Given this list of marker genes PFKFB3, GPD1L, ERICH3, RAP1B, ACTC1, TTC9, NRXN1, TMEM168, PPP3R1, PRDM1 (NCBI Gene Id 639), IKZF2, PHACTR2, TPD52L1, CCDC141, GGACT, SLC16A7, GABRA1, TAOK1, LCA5, GJB7, GABRA5, MAPK1IP1L, BTAF1 (B-TFIID TATA-box binding protein associated factor 1), GPR148, STARD4, ANO4, PNRC2, MTMR2, RAB3IP, AKAP12, ARL17A, PCDH10, EPHA3, RPGRIP1L, LARP1B, SUZ12, CLDN1 (NCBI Gene Id 9076), SLC30A7, RERG, GAB1, CNTN4 (NCBI Gene Id 53943), KCNMA1, CFAP184, FNDC3B, MEGF11, ENOPH1, AFF4, USP15 (NCBI Gene Id 9958), ZNF532, ST18, GPR65, SERPINB5, TMEM64, UBE2T, STAG2, SNRNP48, CNIH1, HECTD2, MEF2A, MIA3, VKORC1L1, PUDP, MSTN, ZDHHC21, RNF216, ATRNL1, TMEM154, ZC3H12B, PNN, MTMR10, ADAM22, BLOC1S6, EVI2B, MSC, INTS8, INO80D, HIPK1, SOS1, TIGAR, SLITRK5, NEXMIF, CRPPA, PROX1, VEGFA, BCKDHB, ATF7IP, PLA2G12A, AP1AR, TMEM108, AKT3, ARAP2, FBXO38, KPNA4 (karyopherin subunit alpha 4), ZNF101, LEPROTL1, GABRB2, DENR, PHF20L1, RNF11, CSNK1A1, ATP7A, DISC1, HTR2C, IGFBP1, RAB22A, FAM76B, SHISA9, LTBP1, TRIQK, CREBRF, ANKS1B, CASP8AP2, ATXN7L3, CD109, VPS13A, SCN2A, SPAG9 (sperm associated antigen 9), CCDC90B, ATP1B1, RORA, ZMIZ1, WDR44, APOL6, LINC03104, RCN2, RAB2B, ATP2B4 (NCBI Gene Id 54594), PDE10A, IQCJ-SCHIP1, ALG10, CDH23, THAP1 (THAP domain containing 1), USP28, GABRA6, ATP6V1A, CCSAP, ARHGEF38, RASSF8, EPHA4, CACNG7, TET3, SLC4A7, FXR1, LINC03105, RPA2, SENP7, PCNA, VCAM1, ABHD13, TARDBP, BRD10, EYA1, UBR2, FBXO27, ZDHHC20, ATRN, DICER1, CDC14A, COL11A1, ZNF281, CARMIL1, SNTG1, CFAP47, TAF1B, TNKS2 (NCBI Gene Id 94771), LEMD3, TRERF1, FMO2, CEP135 (NCBI Gene Id 9662), KLF4, PHC3, WRAP73, DCUN1D4, DAPK1, DACH1, PTGER3, PID1, ENSG00000277067, JADE3, ZNF236, DPYSL2, FKBP14, JAZF1, KCNJ3, SLC2A13, TMEM215, LIPT2, FNIP1, CDK7, WDR7, TMEM51, ADAMTS1, HMBOX1, AK4, SESTD1, INO80, MAP4K3, FAXC, CLTC, DNAAF4, CLEC5A, CHORDC1, APOOL, PUM2, SPRY3, KMT2E, ASPN, PFN2, UNK, TRIM2, TMBIM4, PI15, HIVEP1, HYCC2, NCAM1, SMIM10L1, IL17A, CSN2, SCN9A, DUSP10, OSBPL8, GIGYF2, TAF2, ZNF407, DNAJB4, ALG10B, BNIP3L, NLK, PAXBP1, MKX, INTS15, CTR9, STARD13, SELENOI, SLC6A15, LPP, ANK3, EPPIN, PRRG4, TENT5A (terminal nucleotidyltransferase 5A), VPS35L, PIK3R1, BMS1, RPAP3, SIPA1L3, MSI2, PAX4, here is a description of the gene set: Genes predicted to be targets of miRBase v22 microRNA hsa-miR-5580-3p in miRDB v6.0 with MirTarget v4 prediction scores > 80 (high confidence targets). Human Gene Set: MIR5580_3P studied in species Homo sapiens from publication Chen Y, Wang X (PMID 31504780)